The following is a description of a gene set: Human Gene Set: YKACATTT_UNKNOWN Genes having at least one occurrence of the highly conserved motif M145 YKACATTT in the regions spanning 4 kb centered on their transcription starting sites. The motif does not match any known transcription factor binding site. species: Homo sapiens from publication Xie X, Lu J, Kulbokas EJ, Golub TR, Mootha V, Lindblad-Toh K, Lander ES, Kellis M (PMID 15735639) Comprehensive identification of all functional elements encoded in the human genome is a fundamental need in biomedical research. Here, we present a comparative analysis of the human, mouse, rat and dog genomes to create a systematic catalogue of common regulatory motifs in promoters and 3' untranslated regions (3' UTRs). The promoter analysis yields 174 candidate motifs, including most previously known transcription-factor binding sites and 105 new motifs. The 3'-UTR analysis yields 106 motifs likely to be involved in post-transcriptional regulation. Nearly one-half are associated with microRNAs (miRNAs), leading to the discovery of many new miRNA genes and their likely target genes. Our results suggest that previous estimates of the number of human miRNA genes were low, and that miRNAs regulate at least 20% of human genes. The overall results provide a systematic view of gene regulation in the human, which will be refined as additional mammalian genomes become available., and this is the list of marker genes: PKHD1, PLAG1, PDZD2, LIN54, ADGRB2, HMBOX1, BAG3, WWOX, SKP2, TRPM1, PPP2R2B, STK32C, TGFB2, GIT1 (NCBI Gene Id 28964), OTX2, IRX3, ZNF582, SYT16, SRSF6, NPVF, TMED5, MEIS1, EGFL6 (EGF like domain multiple 6), TAFA1, TRIT1, FIZ1, CCDC50, FGF13, CCDC91, OGA, LINC00649, ARMCX4, RAPGEF6, CBY2, KMT2C, PURA, BET1, TSHZ2, TTN (NCBI Gene Id 7847), PLEKHA5, LIMS1, METTL9, ERN1, EAPP, MRPL34, FGF8, TENM3-AS1, APBA3, IRS1, CATSPER2, APBA1, RAB8B, TTF2, DNAH7 (NCBI Gene Id 56171), PTH2R, UBE2N, RELCH, MFSD14A, GUCA1C, RGS6, ZNF367, NRL, ZNFX1, PCDH11X, TECTA, MLLT3, KRT36, RBBP6, ADD3, INSM1, DHRS4, ZFP2, ZNF524, SS18, ARHGAP24, ATP1B1, ROR1, MAPK10, ZBTB32, MCHR1, COMMD3, OTOP2, DMD, MICAL2, SLC16A6, HHEX, PRPF19, CD27, PLOD2, OMA1, TLK1, SNX17, OTP, RNF10, CHERP, PTPN1, ARF6, ZNF420, BMPR2, LRFN5, ZNF471, CLC, TFDP2, PUS3, ATP2B3, GNRH1, PDLIM3, CD40LG, USH1G, STEAP4, ATP1A4, LEMD1, LRP1B, KLF12, AP3S1, TIAL1, TTC12, PROK2, ZNF654, BARHL2, RNF17, MRPL50, UCMA, CHD2, PRKAG1, DPF2, MEF2C, MAP3K14, SAP130, DDX47, PRDM9, FOXA3 (forkhead box A3), PPTC7, LRRN2, CNTLN, PSME4, LINC00158, MSTN, PYGM, POLE2, FOXN3, SPMIP8, GBX2, DCDC1, GPBP1L1, ZNF570, FAM78A, DPF3, GPR55, STX17, INTS9, EFEMP1, KIF13B, PITPNC1, INPP4B, HOXB8, ZFHX4, HIVEP3, LTBP1, ZNF546, TOB1, FGF10 (NCBI Gene Id 2255), PRDM7, RPP25, VPS41, DYNC1I1, TMEM178A, TPH2, ITPKC, ALKBH8, VASP, EIF4A2, MPI, DUSP10, CABLES1, HSD17B4 (NCBI Gene Id 3295), EBF1, MON1A (NCBI Gene Id 84315), THBS1, NFATC4, NR3C1, GPR21, CASC2, HOXA10 (NCBI Gene Id 3206), SHKBP1, CDC42EP3, BMAL1, CAVIN2, FGD4, CCDC141, MRPL54, PCDH11Y, SH2D2A, COX7B, ELMO1, AMOTL1, EIF2B4 (NCBI Gene Id 8890), RBM39, MUSK, SNX14, FTSJ1, DACT1, MBIP, HAPLN2, DLC1, SYMPK, BAIAP2L1, WSB2, UQCRB, ZNF189, PDK3, MYH8, ZHX2, CCL22, DTX2, SLC2A4, MPZL1, CYLD, SEL1L, BABAM1, ZNF568, ARHGAP12, IGF1, GPR52, OTX1, DDX25, PDE6D, NCK1, NR2F2, PELI2 (NCBI Gene Id 93480), UNC5C, BIRC6, PDIA3, ZFR, BDNF, BIN3, TNFRSF8, AMOT (NCBI Gene Id 23340), LMOD3, TNFSF10, SOBP, PDGFRA, CHCHD7, CLU, SULF1, GARRE1 (NCBI Gene Id 9710), PPIP5K1, TTC1, C19orf18, POLR1B, ENOX2, LMX1B, GDF9, RDH11, COQ8B, TSHZ3, SNX12, RAP1GDS1, PDZRN4, SAMD7, GZMK, CD68, TRPC4AP, ZNF571, PRR5L, CNIH3, PRDM1, LMO3, TP63, PLPP7 (NCBI Gene Id 84906), KRTAP13-2, PIK3R1, OLIG3, KBTBD8, ADAM22, CCDC54, MEMO1, NEUROG1, SFRP1, HOXA3, ATG12, PPARG, RUNX1T1, SYNE2, GLYR1, CHMP4B, PTPRD, GOLPH3L, ZNF569, SMPD3 (sphingomyelin phosphodiesterase 3)